Given this list of marker genes EPHB4, RAC1, ARHGEF7, PAK1, EPHB3, PAK3, MYL12A, EFNB2, EPHB6, SRC, PAK2, EPHB1, NCK2, EFNB3, SDCBP, EFNB1, FYN, GIT1, EPHB2, here is a description of the gene set: Reactome Pathway: Ephrin signaling part of: EPH-Ephrin signaling The interaction between ephrin (EFN) ligands and EPH receptors results not only in forward signaling through the EPH receptor, but also in 'reverse' signaling through the EFN ligand itself. Reverse signaling through EFNB is required for correct spine morphogenesis and proper path-finding of corpus callosum and dorsal retinal axons. The molecular mechanism by which EFNBs transduce a reverse signal involves phosphorylation of multiple, conserved tyrosines on the intracellular domain of B-type ephrins, facilitating binding of the SH2/SH3 domain adaptor protein GRB4 and subsequent cytoskeletal remodeling. The other mechanism of reverse signaling involves the C-terminus PSD-95/Dlg/ZO-1 (PDZ)-binding motif of EFNBs which recruits various PDZ domain containing proteins. Phosphorylation and PDZ-dependent reverse signaling by ephrin-B1 have each been proposed to play important roles in multiple contexts in development and disease (Bush & Soriano 2009). studied in species Homo sapiens